Given this list of marker genes SOS1, FGF2, HRAS, FGF17, FGF18, FGF23, PTPN11, FGF8, FGF16, FGFR3, GRB2, PIK3R1, FGF4, FGF1, FGF5, SHC1, FGF9, FGF20, GAB1, FRS2, FRS3, KRAS, NRAS, PIK3CA, PLCG1, here is a description of the gene set: studied in species Homo sapiens Reactome Pathway: Downstream signaling of activated FGFR3 part of: Signaling by FGFR3 Signaling via FGFRs is mediated via direct recruitment of signaling proteins that bind to tyrosine auto-phosphorylation sites on the activated receptor and via closely linked docking proteins that become tyrosine phosphorylated in response to FGF-stimulation and form a complex with additional complement of signaling proteins. <br><br>The activation loop in the catalytic domain of FGFR maintains the PTK domain in an inactive or low activity state. The activation-loop of FGFR1, for instance, contains two tyrosine residues that must be autophosphorylated for maintaining the catalytic domain in an active state. In the autoinhibited configuration, a kinase invariant proline residue at the C-terminal end of the activation loop interferes with substrate binding while allowing access to ATP in the nucleotide binding site.<br>In addition to the catalytic PTK core, the cytoplasmic domain of FGFR contains several regulatory sequences. The juxtamembrane domain of FGFRs is considerably longer than that of other receptor tyrosine kinases. This region contains a highly conserved sequence that serves as a binding site for the phosphotyrosine binding (PTB) domain of FRS2. A variety of signaling proteins are phosphorylated in response to FGF stimulation, including Shc, phospholipase-C gamma and FRS2 leading to stimulation of intracellular signaling pathways that control cell proliferation, cell differentiation, cell migration, cell survival and cell shape.